The following is a description of a gene set: Mitral valve calcification Human Gene Set: HP_MITRAL_VALVE_CALCIFICATION Abnormal calcification of the mitral valve. species: Homo sapiens, and this is the list of marker genes: ZMPSTE24, SLC34A2, IFIH1, LMNA, FBN1, GBA1, MTX2, HGD